Given this list of marker genes GRM7, ADORA1, NPY5R, PRKG1, TRH, here is a description of the gene set: Any process that stops, prevents, or reduces the frequency, rate or extent of the controlled release of glutamate. Human Gene Set: GOBP_NEGATIVE_REGULATION_OF_GLUTAMATE_SECRETION species: Homo sapiens